The following is a description of a gene set: Human Gene Set: GSE13411_PLASMA_CELL_VS_MEMORY_BCELL_DN from publication Good KL, Avery DT, Tangye SG (PMID 19124732) Enhanced secondary Ab responses are a vital component of adaptive immunity, yet little is understood about the intrinsic and extrinsic regulators of naive and memory B cells that results in differences in their responses to Ag. Microarray analysis, together with surface and intracellular phenotyping, revealed that memory B cells have increased expression of members of the TNF receptor, SLAM, B7 and Bcl2 families, as well as the TLR-related molecule CD180 (RP105). Accordingly, memory B cells exhibited enhanced survival, proliferation and Ig secretion, as well as entered division more rapidly than naïve B cells in response to both T-dependent and T-independent stimuli. Furthermore, both IgM and isotype switched memory B cells, but not naïve B cells, co-stimulated CD4+ T cells in vitro through a mechanism dependent on their constitutive expression of CD80 and CD86. This study demonstrates that upregulation of genes involved in activation, co-stimulation and survival provides memory B cells with a unique ability to produce enhanced immune responses and contributes to the maintenance of the memory B cell pool. studied in species Homo sapiens Genes down-regulated in comparison of plasma cells versus memory B cells., and this is the list of marker genes: RPL10, CD83, TRIM33, REPIN1, USP11, TNFSF13, BPTF, CDC40, STK17B, RPS10, SLC66A2, LYN, PVRIG, PIKFYVE, FNBP1 (formin binding protein 1), CUTC, PDLIM2, KDM5B, LY86, RASSF2, NISCH, ARHGAP25, EIF4B, CAMLG, HLA-DRB6, SKAP2, AIP, EXT2, DET1, TARBP1, SNHG32, HLA-DRB1, STK10, ALOX5, TRBC1, OFD1, IFITM1, CD72 (NCBI Gene Id 971), TGIF1, BTBD7, TRIM14, CCND3, RNF220, SLC25A38, ZFP36L1, INPP5D, PMS2P2, JADE2, NFATC1, SELL, JMJD1C (NCBI Gene Id 9323), UST, RBMS1, CD19, SNX6, BHLHE40, RPS10P5, RPS18, SIDT1, GALNT10, PAK2, PIP4K2A, DOCK2, MYO1F, PRKCZ, ZHX2, NOTCH2, HPS5, NCOR1, C8orf33, SYNGR2, CD53, GGA2, SLC25A36, TAOK3, ZBTB18, EIF3K, IFITM3, CD79B, MDN1, PIK3CD, WASF2, MNT, CYFIP2, HLA-DPB1, PHF11, RPL34, RPS27, RPL31, QRSL1, RPL32, OSER1, RCL1, CRYBG1, SMC6, MAP1LC3B, UBE2Z, NMI, LAPTM5 (lysosomal protein transmembrane 5), UBXN1, USE1, LTB, ALOX5AP, WDR74 (NCBI Gene Id 54663), DCK (deoxycytidine kinase), GIT2, SEPTIN9, BTK, BEND5, FRAT1, RBM38, SYPL1, NAXD, PPP1R16B, WBP1L, SNN, DENND2D, RUBCNL, SYNGR3, SP110, LBH, CTSO, DLST, HLA-F, ATP6V1H, RNF141, ABCB7, CNTRL, DMXL1, RPS12, BIN3, IL16, NUDT3, CHD9, RBCK1, YPEL5, TGFBR2, CD52, HLA-DPA1, BACE2, VPS8, ZCCHC2, RPL23A, P2RX5, INPP5B, ABLIM1, INPP5A, FBXL14, NDRG3, RCN2, ZNF468, ZNF266, CSNK1G2, SP100, RPL41, RIPK2, LCP1, CBLB, HMBOX1, RNASET2, PTPRK, CYBB, NOTCH2NLA, ARHGEF18, MSRA, AKAP10, NAA40, METAP1, PKIG, NECAP2, CD69, FYN, APOH, ZSCAN18, POLR1E, ARHGEF6, MARF1, LAT2, CORO1A, SPAG7, TMEM62, SINHCAF, IFITM2, NELFA, EIF2D, ABCB4 (NCBI Gene Id 5244), HLA-DQB1, ADNP, CD48, RNF44, PFDN5, ARHGAP24, MYD88, DOCK10, PHKB (phosphorylase kinase regulatory subunit beta), BANK1, BLCAP